Given this list of marker genes Cd14, Lbp, here is a description of the gene set: studied in species Mus musculus electronically inferred by orthology from the curated human pathway This event has been computationally inferred from an event that has been demonstrated in another species.<p>The inference is based on the homology mapping from PANTHER. Briefly, reactions for which all involved PhysicalEntities (in input, output and catalyst) have a mapped orthologue/paralogue (for complexes at least 75% of components must have a mapping) are inferred to the other species. Reactome Pathway: Transfer of LPS from LBP carrier to CD14 part of: Toll Like Receptor 4 (TLR4) Cascade